Given this list of marker genes PRKCZ, ARID2, BRAF, ZFPM2, SOX4, SMARCD1, PAH, ROBO1, CXCR4, CHRM3, UBE2A, INTU, PQBP1, GDF1, SHH, FANCE, FOXF1 (forkhead box F1), SKIC2, DGCR8, FANCM, CDON, NXN, SPECC1L, CHD7, PUF60, DOCK6, GAS1, SMARCB1, NIPBL, NKX2-5, EOGT, CACNA1C, UBE4B, ALX3, CASZ1, TBL2, TBX1, NCF1, BRIP1, ROR2, DDX3X, RBM10, MMP23B, GP1BB, ZEB2, UBE2T (ubiquitin conjugating enzyme E2 T), RERE, MAD2L2, SKI, SOX11, FANCF, JMJD1C, FIG4, PDPN, GNPAT, RAB23 (NCBI Gene Id 64438), TGIF1, FANCL (FA complementation group L), FANCC, FANCG, PTCH1, SALL4, RNU4ATAC, PIGN, RBM8A, TUBG1, DLL4, GTF2IRD2, TAB2, ESS2, RPL5, STRA6, SLX4, BAZ1B, XRCC2, STX1A, GATA5, SKIC3, SRCAP, ARVCF (ARVCF delta catenin family member), CCDC22, EIF4H, DPF2, DGCR2, KCNAB2, FOXC2, ARID1A, NOTCH2, SPEN, FANCI, VPS35L (VPS35 endosomal protein sorting factor like, NCBI Gene Id 57020), DDX11, RREB1, FKBP6, COMT, SUFU, CDK8 (cyclin dependent kinase 8), SF3B4, BRCA2, RFWD3, SLC37A4, BRCA1, RPL11, CRIPTO, COX7B, CITED2, VPS37D, GJA5, ARID1B, NIPA1, WASHC5, SF3B2, KDR, NKX2-6, CXCR2, SEMA3E, NOTCH1, DISP1, DGCR6, GTF2I, DACT1, FOXH1, TMEM270, RRAS2, DDX59, RBPJ, GABRD, NODAL, FGFR1, CHUK, HIRA, METTL27, NR2F2, ERCC4, JAG1, LIMK1, FLT4, ELN, TMEM260, CHD4, UFD1, RAD21 (NCBI Gene Id 5885), FANCB, MKKS, SIX3, FGF8, GATA4, ARHGAP31, HIBCH, SLC35A2, RAD51, EHMT1, KMT2D, CLIP2, SALL1, KDM6A, VAC14 (VAC14 component of PIKFYVE complex), ALX1, FANCA, PLXND1, BUD23, RAD51C, SMARCC2, ZIC2, MAPKAPK5, GLI2 (GLI family zinc finger 2), PRDM16, RFC2, NIPA2, FBXL4, DLL1, GTF2IRD1 (GTF2I repeat domain containing 1), GATA6, DNAJC30, LUZP1, HSPG2, DPYSL5, PIGL, SMARCE1, PALB2, SEC24C, TMEM94 (NCBI Gene Id 9772), SMARCA4, BICRA, MYRF, FANCD2, WT1, here is a description of the gene set: Tetralogy of Fallot Human Gene Set: HP_TETRALOGY_OF_FALLOT A congenital cardiac malformation comprising pulmonary stenosis, overriding aorta, ventricular septum defect, and right ventricular hypertrophy. The diagnosis of TOF is made if at least three of the four above mentioned features are present. studied in species Homo sapiens